The following is a description of a gene set: The process in which a relatively unspecialized epithelial cell becomes a more specialized epithelial cell of the mammary gland. studied in species Homo sapiens Human Gene Set: GOBP_MAMMARY_GLAND_EPITHELIAL_CELL_DIFFERENTIATION, and this is the list of marker genes: ZNF703, HOXA5, PRLR, LBH, FOXB1, IRF6, HIF1A, ELF5, ID2, AKT1, SMO, AKT2, FGF2, FOXF1, CEBPB, PTCH1 (patched 1), ERBB4 (NCBI Gene Id 2066, erb-b2 receptor tyrosine kinase 4), LATS1